The following is a description of a gene set: species: Mus musculus part of: Developmental Biology This event has been computationally inferred from an event that has been demonstrated in another species.<p>The inference is based on the homology mapping from PANTHER. Briefly, reactions for which all involved PhysicalEntities (in input, output and catalyst) have a mapped orthologue/paralogue (for complexes at least 75% of components must have a mapping) are inferred to the other species. electronically inferred by orthology from the curated human pathway Reactome Pathway: Adipogenesis, and this is the list of marker genes: Ncor2, Hdac3, Pparg (peroxisome proliferator activated receptor gamma)